Given this list of marker genes HDAC9, LEPROT, RASGRP2, AKR1B1, NCOA1, AIF1, DUSP6, MT1G, LY86, ABCC3, PLAAT4, CPM, SCARB2, NAMPT, FCN1, ZNF804A, VMP1, MFHAS1, LYSET, CYP27A1, PACSIN2, IDO1, TLE4, DHRS4, F2RL1, SLC36A1, LILRA2 (leukocyte immunoglobulin like receptor A2), MT2A, CD55, ATP6V0A1, MS4A6A, TCF7L2, FYN, CPD, PDIA5, STK17B, AMPD2 (NCBI Gene Id 271), ASAH1, CERT1, BCAT1, LPXN, C3AR1, TSPAN3, NCOA4, MSRB2, DDIT4, MX2, HLA-DQA1, HLA-E, FYB1, EPB41L3, SNHG32, CTBS, TIMP2, SON, SORL1, ADAM28, DNTTIP2, SLC43A3 (NCBI Gene Id 55543), HEXB, MAP4K1, CD14, PLSCR1 (NCBI Gene Id 5359), CCRL2, HADHA, PLAC8, MDM1, NRG1 (neuregulin 1), HEBP2, ETS2, LAIR1, PTGER2, ZNF395, NKG7, CMKLR1, KLF10, CRTAM, CD300A, SLC7A7, ZNF185, PHACTR1, MAPRE2, MYD88, CFD, PRKRIP1, BHLHE41 (basic helix-loop-helix family member e41), FPR1, RPL28, PCK2, LTB4R, MIS18BP1, NFATC2IP, IGFBP7, NR4A2, TM9SF4, SEPTIN9, TNK2 (tyrosine kinase non receptor 2), SFPQ (NCBI Gene Id 6421), ACAT1, MCTP1 (multiple C2 and transmembrane domain containing 1), BTN3A3, ICAM3, CALHM2, ITGAL, CCR1, CD2AP, GRPEL1, HDDC2, CACNA2D3, STS (steroid sulfatase), RGCC, FDX1, SLC16A6, DMXL2, SLC30A1, RAB20, STK17A, SPARC, HNRNPA1, CTSK, ARHGEF6, SMAD3, TUBA4A, HBEGF, PLOD3, TRIT1, MT1X, MEF2C, FBP1, ATRX, NOTCH2, LGALS3, SIGIRR, PLTP, EIF2AK2, CCL15, PECAM1, PID1, AQP9, C5AR1, RNASET2, RUBCNL, FCGR1A, DAB2, TLR1, GALC, ICAM2, PDXK, ACP3, SP140L, LILRB4, CHPF2, SP110, SNTB1, CFP, RNF138, CASP1, IFI6, PLA2G7, C3, NPL, SCO2, VSIG4, RNASE4, IRAK3, FERRY3, OAZ2, RHOQ, MT1F, LILRB2, MAN2A2, PLIN2, CCL3, LMO2, IL18, VCAN, MPRIP, SLC2A3, CLEC4E, SPTLC2, DPEP2, NREP, DENND3, PRKCB, PELI1, ITPK1, MT1H, PLCL2, TM6SF1, SPHK1, SGMS1, SCCPDH, SMIM7, HERPUD1, VNN1, FAH, GTF3A, CHST15, SELL, PPM1F, MCL1, EMP1, NRIP3, SLC16A5, MS4A4A, NUP214, ENTPD1, AOAH, CNPY3, RIN2, SPOCK1, CXCL5, ARHGEF40 (Rho guanine nucleotide exchange factor 40), IFITM2, PSTPIP1, CXCL3, FBXL5, OSBPL1A, S100A9, VWA5A, MYOF, FCAR, ALOX5, TFEB, ACADVL, CCNL1, TSC22D1, CD48, SETD1B, EMC7, CD163, MAFB, CTSL, EREG, SOD2, EGR1, ARGLU1, S100A12, RSAD2, STAT1, TCIRG1, PINK1, CD52, LAMP1 (lysosomal associated membrane protein 1), TMX4, RERE, RPS4XP2, ZFAND5, CDKN1C, CCDC69, ACAA2, FKBP4, SIK3, APLP2, SNX10 (sorting nexin 10), C1QA, CALML4, PGS1, METTL9, TREM1, ZNF706, NINJ2, ITGA4, GLA, RPL22, CNPY2, GNS, CHPT1, TBC1D16, ST6GAL1, IL1B, MYO15B, LTA4H, CX3CR1, SH3BP5, SLC35B1, HK2, PTGDS (prostaglandin D2 synthase), AMY1A, SLC31A1, GSR, NKTR, NLRP3, CTSD, IFITM3P7, CYBB, CXCL1, PNP, DECR1, PPIF, CCR5, RGS2, NR1H3, ITPR1, CES1, IQGAP2, NEDD9, CCL2, SUN2, TBC1D1, TEX2, MITF, SGK1, ANP32A, IRAG2, TSEN34, SYF2, ZFP36, ATP13A3, G6PC3, CLEC5A, IMPA2, ARFGAP3, SDR39U1, ANXA5, GADD45G, CXCL10, KLF9, RAP1GAP2, ALDH3A2, here is a description of the gene set: Several hematopoietic growth factors, including interleukin-10 (IL-10) and transforming growth factor-beta1 (TGF-beta1), promote the differentiation of tolerogenic dendritic cells (DCs). Hepatocyte growth factor (HGF) is a pleiotropic cytokine whose effects on human DC differentiation and function have not been investigated. Monocytes cultured with HGF (HGFMo) differentiated into accessory cells with DC-like morphology, released low amounts of IL-12p70 and up-regulated IL-10 both at the mRNA and at the protein level. Upon activation with HGFMo, allogeneic CD4+CD25- T cells expressed the T regulatory (Treg)-associated transcription factor FoxP3, proliferated poorly, and released high levels of IL-10. Interestingly, blockade of surface immunoglobulin-like transcript 3 (ILT3) on HGFMo or neutralization of secreted IL-10 translated into partial restoration of T-cell proliferation. Secondary stimulation of HGFMo-primed CD4+ T cells with immunogenic DCs differentiated with granulocyte-macrophage colony-stimulating factor (GM-CSF) and IL-4 from monocytes of the same donor resulted in measurable T-cell proliferation. HGFMo-primed CD4+ T cells significantly inhibited the proliferation of naive CD4+CD25- T cells in a cell-contact-dependent manner. Finally, DNA microarray analysis revealed a unique gene-expression profile of HGF-activated monocytes. Collectively, our findings point to a novel role for HGF in the regulation of monocyte/DC functions that might be exploited therapeutically. species: Homo sapiens from publication Rutella S, Bonanno G, Procoli A, Mariotti A, de Ritis DG, Curti A, Danese S, Pessina G, Pandolfi S, Natoni F, Di Febo A, Scambia G, Manfredini R, Salati S, Ferrari S, Pierelli L, Leone G, Lemoli RM (PMID 16527888) Human Gene Set: RUTELLA_RESPONSE_TO_CSF2RB_AND_IL4_DN Genes down-regulated in peripheral blood monocytes by CSF2RB (GM-CSF) and IL4.